Given this list of marker genes PRKG1, RGS2, ADORA2B, SOD1, SLC8A1, MIR153-1, ABCC8, GRK2, IRAG1, GUCY1A1 (guanylate cyclase 1 soluble subunit alpha 1), here is a description of the gene set: Human Gene Set: GOBP_RELAXATION_OF_SMOOTH_MUSCLE A process in which the extent of smooth muscle contraction is reduced. Smooth muscle differs from striated muscle in the much higher actin/myosin ratio, the absence of conspicuous sarcomeres and the ability to contract to a much smaller fraction of its resting length. studied in species Homo sapiens